Given this list of marker genes Itgam, C3, C5ar1, C3ar1, Fpr3, Fpr-rs7, Cmklr1, Fpr1, Fpr-rs6, Cr2, Fpr-rs3, Blvra, C5ar2 (complement component 5a receptor 2), Fpr-rs4, Gpr33, Gpld1 (NCBI Gene Id 77224), Fpr2, here is a description of the gene set: Mouse Gene Set: GOBP_COMPLEMENT_RECEPTOR_MEDIATED_SIGNALING_PATHWAY studied in species Mus musculus The series of molecular signals generated as a consequence of a component of the complement pathway binding to a complement receptor. Such components include both whole complement proteins and fragments of complement proteins generated through the activity of the complement pathway.